The following is a description of a gene set: from publication Ivanova NB, Dimos JT, Schaniel C, Hackney JA, Moore KA, Lemischka IR (PMID 12228721) Mouse Gene Set: IVANOVA_HEMATOPOIESIS_MATURE_CELL species: Mus musculus Genes in the expression cluster 'MBC Shared': up-regulated in mature blood cell populations from adult bone marrow and fetal liver. Mechanisms regulating self-renewal and cell fate decisions in mammalian stem cells are poorly understood. We determined global gene expression profiles for mouse and human hematopoietic stem cells and other stages of the hematopoietic hierarchy. Murine and human hematopoietic stem cells share a number of expressed gene products, which define key conserved regulatory pathways in this developmental system. Moreover, in the mouse, a portion of the genetic program of hematopoietic stem cells is shared with embryonic and neural stem cells. This overlapping set of gene products represents a molecular signature of stem cells., and this is the list of marker genes: Xpo7, Paqr9, Lims1, Aak1, Lmtk2, Mob2, Slc66a3, Cpd, Ctsb, Cast (calpastatin), G2e3, Mreg, Tmpo, Smim5, Stradb, Adipor1, Sptb, Pcx, Prc1, Rbfox3, Slfn4, Cir1, Egfr, Ift80, Sowaha, Ints6l, Trim30b, Acsl1, Btnl10, Cd14, Lamp1, Marchf2, Syap1, Cdk8, Tcp11l2, Serinc5, Synj1, Slk, Bmpr1a, Mrpl53, C1galt1, Mgst3, Htatip2, Tmem170, Tspan8, Atp8a1, Dcaf10, Wdr26, Mxi1, Ubac1, 1810037I17Rik, Tmem255a, Tmem9b, Usp32 (NCBI Gene Id 77025), Mrc1, Slc4a1, Mpp1, Hectd1, Ano10, Oip5os1, Ap5s1, Picalm, Upb1, Otud5 (OTU domain containing 5), Fn3k, Wfdc21, Rnf19a, 1810055G02Rik, Cmah, Abca13, Plcb1, P2ry13, Adgrl3, Prpf18, Ergic2, Mtf1, Arl2bp, Sri, C3, Snca, Kdm7a, Ccp110, Lrg1, Eps15, Dio3os, Stk17b, Stmp1, Add1, Abcb6 (NCBI Gene Id 74104), Pirb, St3gal5, Supt4a, Gypa, Dleu2, Ppbp, Nr3c1, Zbbx, Cdca3, Hebp1, Gabpb2, Epor, Ypel5, Arl6ip1, Stx11, Bpgm, Slc66a2, Gucd1, Pi4k2b, Naaa, Stab2, Fam210b, Cpeb4, Tspan17, Daam1, Hgsnat, Colec12, Tfdp2, Tnrc6b, Slc7a8, 1700034G24Rik, Rnf141, Klf3, Sdcbp, Ppp3r1, Cd226, Mospd1, Cdkn2d, Pik3cb, Gpx4, Ear1, Fgr (NCBI Gene Id 14191), Il33, Itgb2l, Cdr2, Atp6v0a1, Cdkn3, Acp1 (NCBI Gene Id 80477), Bmp2k, E2f2 (NCBI Gene Id 329958), Rab6a, Nipa2, Trim59, Usp7, Fpr2, Hemgn, Lilrb4b, Mtss1, Tmx1, 1700063J08Rik, Lnpk, Tmcc1, Atg4a-ps, Sgo2a, Slfn3, Gpatch1, Atp6v1e1, Slc40a1, Usp46 (ubiquitin specific peptidase 46), Sertad3, Rbms1, Slc25a44, Ppox, Tbcel, Cmtr1 (cap methyltransferase 1), Rnf167, Lbr, Fbxo34, Gripap1, Rab11fip4, Pigq, Rmc1, Gpcpd1, Ear2, Cmas, Slc25a38, Alas2, Tcea1, Ap2a2, Mfsd14b, Tm4sf4, Asns, Slc25a37, Noct, Acta2, Cdc42ep3, Fcna, Ftl1-ps2, Etfrf1 (electron transfer flavoprotein regulatory factor 1), Tlr13, Col1a1, Mkrn1, Chp1, Dedd2, Nudt4, Slc30a10, Pithd1, Specc1, Plbd1, Ptdss2, Hace1, H2-T24, Gm26049, Nxpe2, F930017D23Rik, Sh3tc2 (SH3 domain and tetratricopeptide repeats 2), Rab43, Tlr6, Mthfd2, Adgre1, Arhgap19, Ankrd9, Gadd45a, Map4k5, Ccnd3, Kel (NCBI Gene Id 23925), Cops3, Smox, Mir147, Lgmn, Adgre4 (NCBI Gene Id 52614), Agfg1, Nat9, Cldn13, Slc16a1, Wipi1, Riok3, M1ap, Pla2g2f, Sacm1l, Tapt1, Degs1, Tmcc2, Gtpbp2, Slc22a23, Otub2, Eif5a2, Scd1, Rab24, Rad51c, Nhsl2, Ces1d, Trim56, Slc11a1, Macir, Ctsh, Herpud2, Hycc1, St3gal6, C1qb, Stx17, Ifit1bl1, Sertad2, Ly6g, Thbs1, Mmp8, Hagh, Bnip3l, Usp25, Dck, Dgkh, Cybb, Grina, Lpcat1, Gcnt1, Mxd1, 2610020C07Rik, Zfp740, Mindy2, Cela1, Clic6, Acp5, Stx2, Hspa4l, 1700102P08Rik, Rhag, Scrn3, Tlcd4, Fam220a, Relch, Golim4, Lamp2, Gtf2a1, Lyve1, Ehbp1l1, Derl2, Rffl, Tprg1l, Rhd, Ccna2 (cyclin A2), Spta1, Marchf8, Mcub, Ampd3, Endod1, Pglyrp1, Tent5c, Tcp10a, Spdl1, Ninl, Itgam, Slc1a5, Trak2, Lrrc28, Fpr1, Ublcp1, Snx13, Gapvd1, C1s1, Klf11